The following is a description of a gene set: The CDH11 gene consists of 14 exons, which encode two splice isoforms. Both splicing isoforms are expressed in the heart, brain, placenta, lung and bone, but not in the kidney, skeletal muscle, pancreas and liver. Several transcription factors have been shown to directly regulate CDH11 gene transcription, including HOXC8, ILF3, ZEB2, HEYL, FOXF1, and BHLHE22, and the transcription of CDH11 has also been shown to be influenced by a number of growth factors and hormones, such as FGF2, TNF, TGFB1, TGFB2, GNRH1, PTH, dexamethasone, progesterone. CDH11 can also affect TGFB1 signaling, thereby possibly creating a feedback loop. Expression of mouse Cdh11 in mouse osteoblast-like cell line (MC3T3-E1) is not affected by osteogenic hormones triiodothyronine (T3) and 1,25-dihydroxyvitamin D3 at either mRNA or protein levels. part of: Regulation of CDH11 Expression and Function studied in species Homo sapiens Reactome Pathway: Regulation of CDH11 gene transcription, and this is the list of marker genes: HEYL (NCBI Gene Id 92408), PRDM8, BHLHE22 (basic helix-loop-helix family member e22), FOXF1, HOXC8, SP1, ILF3, CDH11, SNAI1, ZEB2